The following is a description of a gene set: species: Mus musculus A complex that catalyzes the transfer of an acetyl group to the N-terminal residue of a protein acceptor molecule. Mouse Gene Set: GOCC_N_TERMINAL_PROTEIN_ACETYLTRANSFERASE_COMPLEX, and this is the list of marker genes: Naa20, Naa15, Naa30, Naa38, Naa16, Naa11, Naa50, Naa35, Naa10, Naa25, Naa12